Given this list of marker genes CBX6, FGF11, NLGN3, PRDM10, GLRA1, MMP14, TRIM46, VCF1, ANXA4, ANK2, NRG1, MAP3K11, MAP1B, NR2F1, ZFP91, ZNF436, ANKRD13B, PHYHIP, SENP1, CS, IMPDH2, STAG2 (NCBI Gene Id 10735), PRDM1, SLC25A4, MLLT10, RIPOR1, CNTN6, HOXC8, ZBTB37, FAM53C, KIF5B, RAB10, PIP4K2B, IRF9, C1QL1, C1orf43, HNRNPR, SEMA6A, CBLN4, PHACTR3, EDA, PLPP3, MAB21L1, NCDN, MOV10, ARMCX4, BAZ2A, CCNYL1, ATF2, PICALM, TGFB1, KATNB1, TNPO3, ZNF436-AS1 (NCBI Gene Id 148898), TPPP3, PCF11, PRMT1, ZNF462, HAUS4, GRIA3, EVX1, PAFAH1B1, DUSP8, ITPR3, PHOSPHO1, NREP, KPNB1, JADE2, MYL3, CITED1, ZBTB32, RGS8, AKIRIN2, PBX1, RAPGEFL1, MAP1A, TNNI1, ELK3, DCLRE1A, ZNF503, ST8SIA1, AGT, RHOA, C14orf119, MGAT3, NTN4, TLN1, SLC4A10, NFIB, ARF3, LIMK2, MCTS1, MNT, ZFPM1, INO80D, EMX2 (empty spiracles homeobox 2), DBNDD2, PAK1, SIX5, CDK5R2, FLVCR2, MPL, CLSTN3, FOXA2, HPCAL1, PSME3, HHATL, IER5L, CA10, GRIN2B, TCTA, ZDHHC8, LUC7L2, HIF3A, RPL10A, NLGN2, PCSK1N, POU3F3, YWHAE, ABI2, KIAA0825, GSK3A, ACVR2B, SYVN1, LRP5, SHROOM1, MTX1, SP4, FGFR1, UBALD1, STMN2, SLC41A1, SNX12, KANSL1L, ACAN, TFAP2B, ATP5F1B, HAUS3, ZMYND8, HOXB9, POU2F1, TPI1P2, NFIX, LMO3, LRCH4, LRP2, NTRK2, AP3S1, GNAO1, HSCB, MXI1, BCL6B, ACIN1, HOXA4, C2CD2L, CD27, SH3GLB2, PCBP4, UBE2A, TLK1, NUFIP2, NKX2-1, MAB21L2, OTX2, PTMS, INTS3, HS6ST3, SLC6A20, FOXP2, NFATC4, NEUROD2, NHLH1, HEXIM2, HOXB6, WASF2, LRP1, DCTN1 (NCBI Gene Id 82109), DSG1, RBP5, KRTCAP2, THBS3, TOB2, SCRT2, ITGA5, PRMT3, FBXO24, MAN2B1, CERCAM, NRGN, PRKAR2B, HOXB8 (NCBI Gene Id 3218), CREBBP, MIXL1, IGFBP5, ARFIP2, PLCB1, SUPT16H, RNF121, RBFOX1, GNGT2, LIN28A, ABI3, BTK, NIPBL, CDKN1C, SPAG9, ATG12 (autophagy related 12), GDPD3, FLT1, CAMK2G, BCL2L2, TGFB3, AGER, SERPINI1, NHLRC2, DHX15, WNT3, BCL11A, RHOBTB2, MEX3B, CKMT1B (NCBI Gene Id 1159), USP31, KCNN3, AJUBA, MSC, CREB3, STMN1, ABCG4, NECTIN1, KRT13, NDN, NEDD4L, ANGPTL7, GUCA2B, BBX, ZIC2, SPTAN1 (NCBI Gene Id 6709), COL11A2 (collagen type XI alpha 2 chain), ZIC5, NFE2L1, DPYSL2, ASIC2, ADAMTS12, CADM1, ZNF532, PTPRN, KCNN2, CBX3, ARHGAP5, RAB11A, HNRNPA2B1, VCAN, PRDM13, MTNAP1, A1CF, TUBB4A, here is a description of the gene set: Genes having at least one occurrence of the motif NNNNNYCACCCB in the regions spanning 4 kb centered on their transcription starting sites. This matches the PAX4 transcription factor binding site V$PAX4_03 (v7.4 TRANSFAC). Human Gene Set: PAX4_03 studied in species Homo sapiens